The following is a description of a gene set: Mouse Gene Set: MIR_92A_3P_MIR_92B_3P species: Mus musculus from publication Chen Y, Wang X (PMID 31504780) Genes predicted to be targets of miRBase v22 microRNA mmu_miR_92a_3p, mmu_miR_92b_3p in miRDB v6.0 with MirTarget v4 prediction scores > 80 (high confidence targets)., and this is the list of marker genes: Itga5, Isca1, Lmbr1l, Fnbp4, Synj1, Fhl2, Ago3, Ube2z, Daam1, Fosl2, Polk, Armc1, Cacna1h, Tsc1, Klhl14, Kcna2, Cep41, Klhl29, Sort1, B230219D22Rik, Ddc (dopa decarboxylase), Ankrd44, Pank3, Fli1, Sertad3, Fhip2a, Insig1, Dock9, Myt1l, Cog3, Ikzf2, Tgif1, Tbl1xr1, Bltp1, Hps6, Syn2, Sh3pxd2a, Scn8a, Tef, Pitpna, Gramd2b, Mapk8, Mia3, Gpc6, Dsc2, Tpcn1, Abcg4, Rnf38, Rnf4, Robo2, Rev3l, Rab23, Robo1, Fmn2, Bcl2l11, Tulp4, Per2, Ankrd28, Mboat2, Tob2, Cyp2d22, Gdf11, Jarid2, Pik3cb, Elk4, Ttc9, Tbx20, Hcn2, Slc38a2, Fbn1, Gata6, Klf2, Acrv1, Dpp10, Fam20c, Ptprk, Edem1, Bahcc1, Stau1, Hivep1, Slc25a36, Csmd3, Npc1, Zfp287, Notch1, Aida, Rbm27, Nufip2, Zfp827, Cd69, Col1a2, Fnip1, Atxn1, Pcdh9, Ewsr1, Lpin1, Itpr1, Rfx1, Wasl, Itga6, Ssbp2, Rsbn1, Rbpj, Zfyve21, Osbpl8, Trim65, Adamtsl3, Prrc2b (proline-rich coiled-coil 2B), Evi5, Wdfy3, Wrnip1, Hnf1b, Rhpn2, Zfc3h1, Wwp2, Adam19, Usp28, Sox11, Prkar1a, Snx13, Stx17, Glra1, Dnaaf9, Gpr180, Evx2, Ubash3b, Slc25a32, Abhd13, Pnisr, Gata2, Xylt2, Dkk3, Adam10, Bcl11a, Iqgap2, Grhl1, Rgs3, Trio, Gsta5, Nsd3, Ppcs, Tafa1, Fkbp1a, Grip2, Ldlrad4 (low density lipoprotein receptor class A domain containing 4), Plekha1, Fzd10, Herpud2 (NCBI Gene Id 80517), Ube2w, Flvcr2, Paxbp1, Pp2d1, Tbc1d12, Nsmf, Peak1, Nol4l, Morc3, Adam23, Bsdc1, Rora, Arf1, Cic, Sgpp1, Atrx (NCBI Gene Id 67403), Chmp7, Ccnc, Gnaq, Pla2g10, Tent4a, Gfpt2, Ergic2 (NCBI Gene Id 67743), Slc6a1 (NCBI Gene Id 232333), Cpeb2, Pitpnm2, Man2a1, Pcdh7, Dcaf6, Appl1, Zeb2 (zinc finger E-box binding homeobox 2), Fbxw7, Slx4, Ptprj, Mylip, Ptpro, Nsmaf, Atxn3, Arrdc4, Slc17a6, Ugp2, Strn3, Map1b, Pcdh11x, Bcl11b, Srpra, Kifap3, Ccnjl, Braf, Kmt5b (lysine methyltransferase 5B), Otud4, A830018L16Rik, Gnpda2, Prkar2b, Adamtsl1, Trak2, Sim2, Glyr1, Itgav, Dennd4b, Dkk2, Tmem229a, Cadm2, Akap10, Nova1, Med19, Dusp10, Kat2b, Cux1, Zfp512b, Gm5148, Myo1b, Snap29, Lhfpl2, Fry, Pik3ca, Zfp521, Nek1, Dus2, Arrdc3, Ibtk, Slco6c1, Jmy, Ddx3y, Bmpr2, Nox4, 1810055G02Rik, Pcgf3, Golga7, Nlgn1, Cldn11, Dmxl1, Klhdc10, Hipk3, Golga1, Nckap5, Pip5k1c, Luzp1, Trim36, Itga8, Ptar1, Hecw1, Ric1, Ranbp9 (NCBI Gene Id 56705), Gsta2, Myo5a, Klf4, Zdhhc5, Itprid2, P3h3, Foxn2, Rgs17, Rad21, Ddx3x, Ezh2, Usp36, Dtx2, Cdk16, Zim1, Stk39, Lats2, Ptger4, Pik3r3, Slc12a5, Atp7a, Plekhm1, Sik1, Nfyc, Snapc1, Gla, Rassf3, Aggf1, Mycbp2, Gpr158, Rab8b, Mfhas1, Fcho2, Fnip2, G3bp2, Mpp1, Fancm, Rab9b, Adcy3, Nefm, Snn, Sfxn1, Tob1, Cnep1r1, Dnajb9, Rbpms2, Herc2, Golga4, Chia1, Btg2, Rab3c (RAB3C, member RAS oncogene family), Slc24a3, Map2k4, Pten, Kcnd2, Phtf2, Col27a1, Hand2, P2ry13, Tcf21, Avl9, Phlpp2 (PH domain and leucine rich repeat protein phosphatase 2), Exoc5, B3galt2, Cdca7l, Sgk3, Dynlt3, Grp, Tead1, Arid1b, Pdzd2, Tagap, Tmem184b, Kcna1, Bcat2, Tmem87a, Greb1l, Glce, Pkdcc, Rpl15, Cpeb4, Gid4, Dennd1b, Galnt14, Xrn1, D16Ertd472e, Cpeb3, Pcmtd1, Fmr1, Asxl2, Pcolce2, Spryd4, Mast4, Baz2b, Nr1d2, Nol7, Ppp1r12c, Ppp1r37, Eomes